The following is a description of a gene set: Mouse Gene Set: chr1C5 studied in species Mus musculus, and this is the list of marker genes: Gm28375, Gpr55, Gigyf2, Gm7582, Gm24555, Alpi, Gm7281, Chrnd, Eif4e2, Daw1, Cul3, Tex44, Rpl30-ps6, Fbxo36, Mir5126, Efhd1 (NCBI Gene Id 98363), 2810459M11Rik, Gm5258, Col4a3, 1700016L21Rik, Mir6353, Gm6189, Gm7592, Mir6344, A030005L19Rik, Gm7544, C430014B12Rik, Gm6136, Gm2389, Rpl19-ps1, Gm16341, Gm18342, Gm17764, Mir8096, Ptma, Nyap2, Gm6264, A030005K14Rik, Nmur1, Gm5530, Alppl2, Gm29371, Tm4sf20, Irs1, A030014E15Rik, Dis3l2, Snord82, C130036L24Rik, Krtap28-10 (keratin associated protein 28-10), Slc19a3, Gm10552, Gm15433, 4933436I20Rik (NCBI Gene Id 75201), Gm18304, Sp100, Gm19552, Ecel1, Kcnj13, A630081D01Rik, Sp110, Gm18180, A630001G21Rik, Gm7516, Armc9, Mir3535, Psmd1, Gm22786, Slc16a14, Chrng, Dock10, Cops7b, Gm28626, Pde6d (phosphodiesterase 6D, cGMP-specific, rod, delta), A030003K21Rik, 9830004L10Rik, Snora75, Ccl20, Cab39, Gm26187 (NCBI Gene Id 115487620), Krtap28-13 (NCBI Gene Id 71386), B3gnt7, Sp140, Gm53056, Sphkap, Gm6244, Gm19257, Gm6374, Htr2b, Gm6198, Gm6217, Spata3, Sp140l1, Gm28940, Nppc, Akp-ps1, Gm2619, Agfg1, Ncl, Sp110-ps1, Rhbdd1, 9930111H07Rik, Gm2427, Mff, Trip12, Gm7553, 4933407L21Rik, Pid1, Gm7539, Prss56, Fam124b, Itm2c, Gm7609, Sp140l2, Akp3, A530040E14Rik, Dner, Col4a4